Given this list of marker genes GFRA1, SORT1, NTRK1, NTRK3, NTRK2, here is a description of the gene set: Combining with a neurotrophin, any of a family of growth factors that prevent apoptosis in neurons and promote nerve growth, and transmitting the signal to initiate a change in cell activity. studied in species Homo sapiens Human Gene Set: GOMF_NEUROTROPHIN_RECEPTOR_ACTIVITY